The following is a description of a gene set: Binding to an inositol-containing glycerophospholipid, i.e. phosphatidylinositol (PtdIns) and its phosphorylated derivatives. Mouse Gene Set: GOMF_PHOSPHATIDYLINOSITOL_BINDING studied in species Mus musculus, and this is the list of marker genes: Tom1, Snx30, Snx16, Phlda3, Exoc1, Zfyve26, Hgs, Ldlrap1, Dnm2 (dynamin 2), Arap3, Pfn2, Zfyve1, Myo1g, Stam2, Tom1l1, Tulp1, Dab2ip, Snx19, Fes, Snx24, Zfyve9, Arhgap9, Snx31, Esyt2, Pitpnb, Fcho2, Defb3, Syt7, Dok7, Gsdme, Dpep1, Snx4, Fuz, Sh3pxd2a, Snx17, Fermt2, Vps36, Tecpr1, Frmpd2, Snx13, Plekhn1, Tulp3, Trpv1, Sgk3, Syt5 (synaptotagmin V), Picalm, Rbsn, Exoc8, Fundc2, Adap1, Myo10, Ogt, Gsdmc2, Jph2, Snx25, Defb6, Gsdmc4, Clvs1, Phlda2, Pard3b, Pld1, Wdr45, Avil, Gsdma, P2rx2, Aida, Bcas3, Hcn1, Myo1b, Cyth3 (cytohesin 3), Nrgn, Dennd1a, Plekha5, Atg2b, Clvs2, Sh3pxd2b, Ceacam2, Anxa8, Pirt, Arhgap33, Fchsd2, Kcnq1, Actn2, Osbpl8, Gap43, Arap2, Gbf1, Atp13a2, Dnm1, Appl2, Plekhb2, Tirap, Ceacam1, Osbpl5, Hip1, Commd1, Ccdc88a, Pitpnc1, Snx8, Racgap1, Esyt3, Rs1, Defb7, Osbpl2, Mbl2, Thy1, Gsdmd, Snx11, Kcnj3, Dennd1b, Snx27, Laptm4b (lysosomal-associated protein transmembrane 4B), Akt1, Amer1, Chmp3, Plekhf2, Asap1, Snx12, Ttpa (tocopherol (alpha) transfer protein), Gga1, Rph3a, Pld2, Rubcnl, Pfn1, Rcsd1, Btk, Ap2a2, Gramd2a, Itpr2, Gsdma3, Ncf4, Scin, Mtss2, Gsdma2, Iqgap1, Amer2, Gsn, Capg, Arfip2, Hip1r, Iqgap2, Rag2, Snx7 (sorting nexin 7), Epb41, Zfyve16, Sytl2, Pigu, Sdcbp2, Plekha4, Snx18, Snx32, Phlda1, Ttpal, Fzd7, Grb7 (NCBI Gene Id 268479), Svil (supervillin), Vill, Syt1, Snx22, Snx3, Wdfy1, Sh3yl1, Ncf1 (neutrophil cytosolic factor 1), Mtm1, Stam, Rab35, Dennd1c, Npm1, Fcgr4, Veph1, Plcb1, Esyt1, Snx14, Pard3, Syt10 (synaptotagmin X), Defb5, Wdfy3, Snx5, Alox15 (NCBI Gene Id 11687), Slc9a3, Tom1l2, Inppl1, Eea1, Pla2g4e, Pask, Itpr3, Snx33, Dapp1, Gga3, Mreg, Mitd1, Mapkap1, Plcd1 (phospholipase C, delta 1), Mbl1, Defb8, Plek2, Nisch, Bbs5, Krit1, Cgas, Snx21, Obscn, Flii, Kcnj1, Nlrp3, Wipi2, Intu, Snx1, Syt9, Lancl2, Gpaa1, Pitpna, Plekhf1, Arhgap32, Washc2, Arap1, Amer3, Itpr1, Gab2, Dab2, Syt3, Rps6kc1, Snx29, Anxa2, Frmpd4, Tpcn1, Ing2, Snx10, Gsdmc3, Rubcn, Bltp2, Fgd2, Noxo1, Tnfaip8l3, Sestd1, Pitpnm1, Gga2, Numa1, Snx6 (sorting nexin 6), Pik3c2g, Hs1bp3, Golph3, Kcnh1, Phf12, Plcz1, Appl1, Cidec, Rnf34, Snx2, Ankfy1 (ankyrin repeat and FYVE domain containing 1), Sbf2, Apba1, Twf1, Vps13b, Kif16b, Wipi1, Wdr45b, Kcnj2, Pxk, Tpcn2, Fundc2b, Zfyve19, Rlbp1, Mcf2l, Vil1, Zfyve28, Plekha8, Pik3c2a, Cfl1, Irgm1, Adap2, Zcchc14, Snx20, Tln1, Wdpcp, Snx9, Septin5, Snx15, Golph3l, Cadps, Rufy4, Acap2, Gsdmc, Defb4, Mark1, Exoc7, Atg2a, Osbp, Pxdc1, Pitpnm2, Sap30l, Vnn1, Myo1e, Twf2, Plekha3, Arfip1, Mppe1, C2cd2l, Cert1 (ceramide transporter 1), Pla2g4a, Snap91, Sdcbp, Zcchc2